The following is a description of a gene set: A cyanobacterial LPS antagonist prevents endotoxin shock and blocks sustained TLR4 stimulation required for cytokine expression. We report the identification and biologic characterization of an LPS-like molecule extracted from the cyanobacterium Oscillatoria Planktothrix FP1 (CyP). Human Gene Set: GSE4748_CTRL_VS_CYANOBACTERIUM_LPSLIKE_STIM_DC_1H_UP Genes up-regulated in monocyte-derived dendritic cells: untreated versus LPS like antigen from O. planktothrix (1h). studied in species Homo sapiens from publication Macagno A, Molteni M, Rinaldi A, Bertoni F, Lanzavecchia A, Rossetti C, Sallusto F (PMID 16717116), and this is the list of marker genes: GTF3A, STK24, DCAF13, CCND1, NDUFS3, LRRC20, SLC14A1, NENF, AP2B1, IQGAP1, UBE2D2 (NCBI Gene Id 7322), HSCB, CASP4, TARS1, SIL1, BCL2L11, SLC22A23, ZWINT, EFNB2, PFN2, DNASE1L1, NTN1, TUBA3C, KRTAP19-3, PDRG1, BCS1L, PRPSAP1, MORF4L1, SMYD2, FAIM, EBNA1BP2, CRYZL1, PPP1R15A, PTBP3, FEM1B, NOP2, AMBN, NPM3, STRN, KRI1, TMEM176A, AFP, JAGN1, TRRAP, OLIG2, FAAP20, NTAN1, SORCS3, CHST1 (NCBI Gene Id 8534), APBB2, RAB13, HPRT1, HECTD1, BIK, PTPA, YAP1, PIAS1, LIN37, MPST, RPS27, AIG1, ZCCHC17, CAB39, PTGR3, EP400, CDC42EP5, ANAPC5, BTG3, ATP6V1E1, AMPD3, CLASP2 (NCBI Gene Id 440948), FOS, KTI12, TMEM176B, C8orf33, GREM1, ADGRA2, LITAF, RAP2C, IL13RA2, TSPAN5, RAP2A, ATXN7L1, B4GALT4 (NCBI Gene Id 8702), COQ9, TP53INP2, IL1RL1, CCND2, RGCC, SPRED2, SUN2, CEPT1, SSB, CUEDC2, LIMD1, BHLHE22, PSMB2, FAM32A, RAB5C (NCBI Gene Id 5878), PSMD12, C1QBP, PIGF (NCBI Gene Id 5281), KDM3B, SIN3A, AHI1, CFL1, NNT, CNOT1, JPT1, APOBEC1, TRIR, C9orf78, SLC38A2, BST2, RALA, RBM10, AP3B1, SOX18 (NCBI Gene Id 54345), POLR2M, TM4SF1, PDE4B, UBQLN2, TPM2, SLC35F5, OXR1, RAI14, FRG1, B4GALNT1, IFIT2, ATF1, AMPD2, ANTXR2, SIGMAR1, SEC23B (NCBI Gene Id 980), IGFBP6, DNAJC21, CFDP1, SSU72, C19orf53 (chromosome 19 open reading frame 53), BOLA2, CLMP, DNAJC30, XPNPEP1, STX8, TNFRSF12A, CDC42EP1, ATP6V1G1, NDUFA11, PRDX3, TMEM115, CDC123, NIPBL, RPL41, IFITM2, ADRB3, CLRN3, BLTP2, CCN4, TNS2, EEF1D, RAPGEF1, SUPT16H, YIF1A, ATXN7L3B, LAMA1, ASF1A, UBQLN1, LSM1, DEPDC7, TNNI1, COX8A, DQX1, EGR2, LRIG1, PCOLCE2, TOPORS, FSTL1, PLEC, PLPP3, TMEM222, CASP6 (NCBI Gene Id 839), SNW1, SH3BP5L, DPH5, SPR, GYPC, ATP5MC2, RLF, UBE2K, TMTC4, TSTD2, MFSD5, NLGN2, DTX2, HSD17B1, PHC2, TUT1, FBXL20, GCH1, ENC1